Given this list of marker genes ZNF598, MMP3, BAX, CDK5RAP3, EXOC8 (NCBI Gene Id 149371), PIK3R1, GSPT1, NAPA, HSF1, MMP1, ASCC3, SVIL (supervillin), CHMP4C, ATAD2, CHMP3, DNASE2, DFFB, PTRH1, CTSK, APC, MTPN, PEX12, ITGB1, ADAM10, EEF2K, EIF4E2, TRIP4, C1QA, UPF1, DCTN1, KLK7, KLC1, ATG5, BMERB1, VRK1, GBF1, STMN1, SH3BP1, LIMA1, ARHGEF2, ASPH, RCHY1, PLAAT1, SPTB, PNPLA2, STX17, VPS16, VPS33A (VPS33A core subunit of CORVET and HOPS complexes), FURIN, GABARAPL2, KIF24, MICAL2, ITGAM (integrin subunit alpha M, NCBI Gene Id 3684), NCKAP5, VAMP8, SMARCC1, BLCAP (BLCAP apoptosis inducing factor), VPS4A, WASHC2C (WASH complex subunit 2C), CIB1, MAP1A, SMARCB1, DNASE2B, ENDOG, PELO, MID1IP1, CHMP6, MRRF, FER (NCBI Gene Id 2241, FER tyrosine kinase), ATAD2B, TRIM21, IL6, ZFAND1, PLEK, UFL1, PRKAA1, MMP10, AURKA, CAPZA3 (capping actin protein of muscle Z-line subunit alpha 3), KAT5, CST3, VTI1B, MMP13, KIF2A, MTRFR, SYNJ1, PEX2, PIF1, LPIN1, VCP, BECN1, CHMP7, MMP20, PLK3, TWF2, TRAF2, KATNB1, TSG101, SHARPIN, ELP6, MTIF3, FGFR4 (fibroblast growth factor receptor 4), SET, MTRF1L, ASCC2, KLK5 (kallikrein related peptidase 5), PLXNC1, NEK6, NEDD9, MAP1LC3B, PLAAT3, ELAC1, INSR, NSF, C1QL1 (complement C1q like 1), CLN3, CRACD, DNAJC17, ATP2A2, GPER1, KIF2B, SARM1, SPTBN5 (NCBI Gene Id 51332), GAK, KIF19, VMP1, TECPR1, ADD1, PAFAH1B1, APC2, HEMK1, SH3PXD2B, DYRK3, TTBK2, IL1B, DDR2, PRSS2, EPS8, TMOD3, ADD3, CHMP2B (charged multivesicular body protein 2B), ADAMTS15, ARID2, TAOK1 (NCBI Gene Id 80214), TMPRSS6, SPTAN1, ZMPSTE24, ADGRB3, VPS33B, MMP15, TNP1, SPEF1, ANKZF1, SWAP70, NMNAT1, BOK, PLG, MFSD8, KIF5B, DUSP3, PPP1R10, HPN, ADAM15, MMP9, SSRP1, EPG5, STMN4, ETF1, TRPV4, DKK1, SMARCC2, TPSAB1, LRP1, FGF13, GAS2L2, SNAP29, LMOD1, COL6A1, TIMP3, DIAPH3, MAP1B, SMCR8, SMARCA4, RPL23, ABCE1, C1QC, LCP1, CHMP2A, SCIN, LMOD3, MIR92A1, ACVR1C, ADAMTS5, PPP1CA, AVIL, SPTA1, PEX10, WDR1, PBXIP1, TBC1D25, DICER1, GABARAPL1, EIF5AL1, SAYSD1, MTIF2, MIR29B1, MAP4, VTA1 (vesicle trafficking 1), TMOD2 (NCBI Gene Id 29767), IST1, CLASP2, NCKAP5L, CAPZA2, CLTC, TRIM58, MYLK3, GTPBP2, AURKB, KIF2C, TREM2, IQSEC1, TRNT1, GABARAP, CHMP1A, MMP12, TNF, CDK1, MID1, STMN3, C3, FLII, MAPRE2, CAPG, NAV3, RNF25, CHMP1B (charged multivesicular body protein 1B), HDAC6, APEH, ARF6, TMOD1, MIR195, FAP, CHKA (NCBI Gene Id 1119), CTDNEP1, IRGM, ATR, CHMP5, OGFOD1, DDIT4, TMEM39A, DDR1, ADAM8, MMP19, SETX, MAP1LC3A, VPS54, RDX, SCAF8, VAMP7, GRWD1, MAP1LC3B2, CAPZA1, ATXN7 (ataxin 7), ADD2, SNAI2, NAPB, PEX5, HSPA2, MAP6D1, SCAF4, GSN, UBQLN4, CAPN10, IGF1R, MICAL3, ELANE, RRP7A, GSPT2, PRKAA2, KIF14, SMARCD2, SMARCD1, NEMF, MIR98, TOM1, JMJD4, SPECC1L, PHF23, NEMP1, TCF25, TOP2A, SEMA5A, CCDC88C, VPS4B, CLASP1 (NCBI Gene Id 23332), SPTBN1, KIF18A, NES, PDXP, PLK1, WDR47, SMARCE1, HDGFL3, CHMP4B, MIR24-1, DDRGK1, STAT3, MIR29C, AFG2B, FAF2, WASHC1 (WASH complex subunit 1), PDPN, ADRB2, MAP1LC3C, KLK4, CAPZB, PRKCB, IRAK3, RAC1, UFSP2, PLIN2, MMP14, FYCO1, RACK1, TPX2, MMP2, DEDD2, LIX1L, TMOD4, PRSS1, SMARCD3, SNX14, EXOG, EIF5A2 (NCBI Gene Id 57114), KLHDC10, CCSAP, TGFB1, MCTS1, PIK3C3, PEX14, GATA5, CTSG, TFIP11, ASB2, PPP1R9B, DNASE1L3, DFFA, TGFB3, FSCN1, BNIP3, LAMP2, MAP1S, ERN2, CALCOCO2, CFL2, MMP7, GOLGA2, GABARAPL3 (GABA type A receptor associated protein like 3 (pseudogene)), MICAL1, PRKCA, TGFB2, AKAP8L, GFM2, VIPAS39, C1QB, LTN1, PLIN3, SKIC3, VILL, RUBCNL (NCBI Gene Id 80183), UBQLN1, CARMIL2, DSTN, DPP4, WIPI2, WNK1, MYC, SNAPIN, HSPA8, SPTBN4, H2BC1, GIGYF2 (NCBI Gene Id 59281), MMP11, CIDEA, CKAP2, APAF1, RAC2, PYM1, CTSV, KIF18B, SMAD7, MRPL58, PLEKHH2, TRIOBP, VANGL2, GAS2L1, H2AC25, SHFL, DNAJC6, ACTN2, MIR205, HMGA1, SKIC8, MTRF1, DMTN, CHMP4BP1, KIF21A, LIX1, NOXO1, RSPH6A, KIF9, SKIC2, TWF1, MELTF, MCOLN1, STMN2, EIF5A, STON1, ACIN1, MAP4K4, LMOD2, ARID1A (NCBI Gene Id 8289), CFL1, NFE2, FLOT1, ATG12, TRIM54, GCN1, ADAMTS4 (NCBI Gene Id 9507), CX3CL1, CALM1, ATG14, MMP8, PIK3CA, RUBCN, EIF2D, UVRAG, CKAP5, CTSS, CLEC16A, CX3CR1, STX5, RECK, SPTBN2, SUPT16H, NGEF, CMA1, CAMSAP2 (NCBI Gene Id 23271), EPHA4, CECR2, CHMP4A, USP10, KCNK13 (potassium two pore domain channel subfamily K member 13), ABCC8, BBOF1, TGFBR1, SPAST, VIL1, PRICKLE1, SLN, MTRES1, ENG, PIK3R4, F2RL1, HBS1L, RNF14, DENR, FOXL2, CARMIL1, LAMC1, here is a description of the gene set: species: Homo sapiens Human Gene Set: GOBP_CELLULAR_COMPONENT_DISASSEMBLY A cellular process that results in the breakdown of a cellular component.